The following is a description of a gene set: studied in species Homo sapiens Reactome Pathway: RNA Polymerase III Transcription Initiation There are three basic types of RNA polymerase III promoters. The three types of RNA polymerase III promoters are known as type 1, type 2, and type 3 promoters. Type 1 promoters are found in the 5S genes and consist of a gene-internal element called the internal control region (ICR), that is subdivided into A block, intermediate element, and C block. Type 2 promoters are found in tRNA genes, Adenovirus 2 VAI gene, and other genes. These promoters consists of two gene-internal elements called the A and the B boxes. Type 3 promoters consist of a distal sequence element (DSE) that serves as an enhancer, a proximal sequence element (PSE), and a TATA box. <p>Some promoters combine elements from type 2 and 3 promoters. For example, the S. cerevisiae U6 promoter, also shown in the figure, contains the TATA box typical of type 3 promoters and the A and B boxes typical of type 2 promoters. Moreover, in S. pombe, nearly all tRNA and 5S genes contain a TATA box in addition to gene-internal elements, and the TATA box is required for transcription. part of: RNA Polymerase III Transcription, and this is the list of marker genes: POU2F1, POLR3G, POLR3B, POLR3D, GTF3C5, BRF1, BDP1, POLR3K, GTF3A, GTF3C2, CRCP, POLR2E, POLR3C (NCBI Gene Id 10623), SNAPC1 (NCBI Gene Id 6617), SNAPC3, POLR3H, POLR3A, ZNF143, BRF2, POLR1C, POLR3E, POLR3GL, SNAPC5, TBP, POLR2F, GTF3C1, GTF3C6, SNAPC2 (NCBI Gene Id 6618), POLR1D (RNA polymerase I and III subunit D), GTF3C3, SNAPC4, POLR3F, GTF3C4, POLR2L, POLR2H, POLR2K